Given this list of marker genes Prkd1, Pck1, Fos, Btg2, Map4k1, Rplp0, Grip1, Cdk4, Adam15, Sphk2, Fbp1, here is a description of the gene set: Any process that results in a change in state or activity of a cell or an organism (in terms of movement, secretion, enzyme production, gene expression, etc.) as a result of a phorbol 13-acetate 12-myristate stimulus. Mouse Gene Set: GOBP_RESPONSE_TO_PHORBOL_13_ACETATE_12_MYRISTATE studied in species Mus musculus